Given this list of marker genes DUSP13B, TNKS2, FAM219A, CD63, GAL3ST3, CAMTA1, PAXIP1, NHS, SMG1 (NCBI Gene Id 23049), OXR1, TRMU, NRIP1, ZNF395 (NCBI Gene Id 55893), DIPK2A, ACACA, MSI1, LUC7L, MTERF4, SLC35A4, RAB1B, TGFBR1 (transforming growth factor beta receptor 1), SZT2, PAPPA, FBXL19, SLC1A3, FAM76A, RASAL2, SUGP1, AHCTF1, SLC39A14, PRKX, UBFD1, SMARCD1, NR2C2, SMURF1, SCRT2, TAF5, DDX17, KCNK7 (NCBI Gene Id 10089), ERC2, ARHGAP33, PCBP2, NUFIP2, SLC6A6, GTDC1, PPME1, SCN4B, GNB2, PATZ1, HMGA2, NPM1, HAPSTR1, ETF1, SOX11, PSME3, MBLAC2, SETD2, PAPOLA, HIC2, OGT, MDGA2, GGT7 (NCBI Gene Id 2686), PCBP1, AVL9, PBRM1 (NCBI Gene Id 55292), here is a description of the gene set: studied in species Homo sapiens Genes having at least one occurence of the motif CCAGGTT in their 3' untranslated region. The motif represents putative target (that is, seed match) of human mature miRNA hsa-miR-490 (v7.1 miRBase). Human Gene Set: CCAGGTT_MIR490